Given this list of marker genes SEC61G-DT, H2BC12, ENDOV, IRGQ, HP1BP3, AP4E1, UBE2F, PSTK, RPS6KB1, MCRS1, H2AC21, ANKRD24, TOLLIP-DT, FUT8, CHCHD4, LINC03014, PAIP2, HNRNPA1, H2AC11, TUBD1, SIN3B, SMAD5, CHD1, H2AC14, ZNF12, H2BC21, THAP7-AS1, H1-4, PRKRIP1, VMAC, KHDRBS1, VPS26B, FADD, COG3, H2AC17, CXorf38, HMGB3P22, NAGK, BLOC1S4, ZBTB40, ANKRD26, NDEL1, H4C5, MIR5696, PITPNB, GPRC5D-AS1, H4C3 (NCBI Gene Id 8364), MRFAP1L2, POU2F1, PAGR1, H3C10 (H3 clustered histone 10), NCAPD3, SELENOI, SAYSD1, CHD1-DT, DPF2, ARRDC1-AS1, PPP6R1, PHF23, RNF149, ARMT1, RBM17, H2AC6, TOLLIP, TMEM250, SNORA14B, LSM7, H2AC16, MST1P2, CCDC12, RANBP3-DT, IFNAR1, SCML1, CORO7, TIMM13, GPI, RNF213-AS1, RNF19B, C10orf88, H1-2, H4C4, NUP93, VRK3, UBE2V1, RPP38, TMEM79, H2AC13 (NCBI Gene Id 8329), SPPL2B, PHF8, POU2F1-DT (NCBI Gene Id 118568815), NDUFA11, EMC10, SSR3, POLA2, DNAJA3, CKLF, NBPF1, PRPF40B, PHF12, MRPL45P2, ARMC6, MRPL45, GDF5, CISD1, LARS2, GLG1, CBX5, HNRNPL, FXR2 (FMR1 autosomal homolog 2), INKA2, INTS13, SMARCA4, PABIR1, SLC2A11, RPP38-DT, EXOC8, RAB18, SNAP23, TK2, LINC03015, CD320, TMEM141, SPRTN, AKTIP, ITFG2-AS1, EID2B, TFPT, COPS7A, EEF1AKMT1 (EEF1A lysine methyltransferase 1), SRRM5, MIS18A, SUGP2, ZNF248-AS1, H2BC5, LIPT2-AS1, KDM3A, MORN5, CDK12, RANBP1, CDC42EP4, GNB1L, PREB, POLR2M, SIRT6, LONP1, RANBP3, TOMM20, NUP93-DT, SEC61G, H2AC4, MOK, CEP250, ZBTB17, PDRG1, ATP5MC3, LIPT2, ARHGEF37, H4C8, GTF3A, FAM24B, POLD3, SMG5, DAGLB, MLST8, CSNK1A1, MIR1289-1, SAMD1, PRELID2, BNIP3, MRPS14, ASPSCR1, H2BC18, NDUFA8 (NCBI Gene Id 4702), TXNL1, H2AC20, MRNIP-DT, H4C16, RMND1, LINC02482, ZDHHC5, CANX, NVL, H2BC11, UPF2, FGFR1OP2, EHMT1, PRKAB2, WWP1, C10orf88B, H3C4, JMJD4, XRCC5, SDCBP, CDC7, MRNIP, H4C12, FAM220A, VAPB, SNAP47, GARIN5A, NANS, H4C11, NAPG, H4C2, TMEM43, ZNF875, H2BC16P, RRP1 (NCBI Gene Id 8568), ADGRF3, FBRS, CCDC7, H2BC13, MTCH2, N6AMT1 (N-6 adenine-specific DNA methyltransferase 1), THAP7, MIR3143, VPS51, RTL10, KIF3B, HINFP, YEATS4, H2BC4, RAB35, GNPDA2, LRRC27 (NCBI Gene Id 92295), WDR43, ZNF576, FUT8-AS1, ENTPD6, ANGEL1, H2AC12, PRELID3B, RAB35-AS1, FAM98A, THOC3, RPRD2, PVR, CPLANE2, ZNF248, ZNF473, PRPF31, ZNF106, DEDD2, RPL27, H4C1, MAN1B1-DT, TRMT2A, ATP6V0E2, H2BC17, PIPOX, EIF3E, NPRL3, FAM222B, ENSG00000235979, CKLF-CMTM1, H3C1, VDAC3, RFX2, RPL36, UBE2F-SCLY, SRSF10, CHMP7, RTRAF, CROCCP2 (CROCC pseudogene 2), CATSPERD, SCAF11, TTC28-AS1, H2BC14, PGS1 (NCBI Gene Id 9489), BOLA1, SNX1, HINT1 (NCBI Gene Id 3094), ZC3H8, H3C12, ATP6V0E2-AS1, STK32C, ARPC2, MAN1B1, IQCC, CGREF1, here is a description of the gene set: species: Homo sapiens Human Gene Set: NPAT_TARGET_GENES Genes containing one or more binding sites for (NPAT) in their promoter regions (TSS -1000,+100 bp) as identified by GTRD version 20.06 ChIP-seq harmonization. from publication Yevshin I, Sharipov R, Kolmykov S, Kondrakhin Y, Kolpakov F (PMID 30445619)